Given this list of marker genes PGAP1, HECW2, CARS1, DNM2, MORC2, TUBB3, CWC27, IQSEC1, TRAPPC9, SATB1, SUPT16H, KDM5B, NEUROD2, SELENON, GJA1, COL3A1, LIPT2, POMT2, GJC2, NFIA (NCBI Gene Id 4774), MBTPS1, ATP10A, BSND, KMT2C, CYP3A4, CPLX1, ZNF407, AP4E1, FBLN1, SPG11, FUS, SLC18A2, CLCN7, CUL3, P4HTM, OTUD7A, CACNA1C, TAF1, FOXP1, KLHL15, MECR, LSS, COL6A3, YARS1, GET4, TNRC6B, NGLY1, AMPD2, LAMA2, CAMK2A, HS6ST2, FITM2, ATP6V1A, FNIP1, SLC37A4, CSNK2A1, POMT1, GAA, WASHC4, CHRND, SCN4A, EIF2B4, GALNT2, ZC4H2, NCAPG2, OTUD6B, MTPAP, CFL2, CTNNA2, MBD5, VPS51, PGAP3, EXOC6B, XYLT1, AGRN, BCORL1, ASXL3, MYO9A, YIF1B, DPH2 (NCBI Gene Id 1802), PLEC, COASY, KCNK4, CCDC22, SMC1A, ALG12, TPM2, PPP2CA, HNRNPK, CNOT3, GLS, MMAB, CACNA1G, MBOAT7, COG1, MAPK8IP3, RTN2, LNPK, PUM1, CDKL5, TBR1, LRP5, NMNAT1, NEXMIF, LARS1, CRBN, TTN (NCBI Gene Id 7847), ZNF142, VPS35L, FIG4, PAFAH1B1, CADM3, FDXR (ferredoxin reductase), PRIM1, TNFRSF11B (NCBI Gene Id 4982), CHRNB1, PNP, PLAA (NCBI Gene Id 9373), SCO2, LMNB1, MUSK, BRAT1, PACS2, PHKG2, STAG2, SET, CHAMP1, DDOST, SON, FLVCR1, EIF4A2, CDC40 (NCBI Gene Id 51362), SLC39A8, SLC12A2, POLR1A, KCNA4, TMEM94, BCL11A, SLC25A12, MARS1, TSEN15, ACTA1, RAB11B, COL2A1, EIF2AK1, ZEB2, CUBN, DHPS (NCBI Gene Id 1725), CLCNKA, DYNC1I2, ADCY5, VLDLR, PHEX (phosphate regulating endopeptidase X-linked), CHMP1A, KDM4B, POLR1C, TNPO3 (transportin 3), NUBPL, WLS, GALE, MYT1L, BIN1, NAT8L, SLC31A1, RBPJ, DLK1, RETREG1, EXTL3, OGDH, HNRNPC, BMP1, ATG7, DOK7, JAG1, MINPP1 (NCBI Gene Id 9562), MECP2, CIT, SMARCD1, GALNS, PPP2R5D, WDR4, TMEM63C (transmembrane protein 63C), FMR1, SIK3, TMEM163, TRIM2, HMBS, KDM1A, SNX14, RNU4-2, NCDN, RYR1, SIGMAR1, SCN2A, KMT2E, SEMA6B, CRELD1, KIF14, KY (kyphoscoliosis peptidase), LMNB2, ATP1A1, HARS1, FBXO11, POMK, KAT6A, CHRNA1, MKS1, PPP2R1A, WDR81, FRMPD4, KIAA0753, HDAC4, ASCC3, COL12A1, DLAT, H3-3A, TRPM3, CTBP1, SCAF4, RTL1, SDHB, UBE3A, NTNG1, TAF4, TRNT1, PIEZO2, TTC5, FGF3, NAA10, SOX4 (SRY-box transcription factor 4), SELENOI, AP1S2, UBE2A, AMN, DAG1, RUBCN, RALA, CLDN11, GPRC5B, KLC2, RORA, CNKSR2, MEGF8, FLRT1, TRAPPC10, MYF6, MRPS14, SMARCA2, ALMS1, DPM3, GNPTAB, CCDC134, KARS1, ERLIN2, COL1A1, WDR45, RAB3GAP1, PAK3, SPTSSA, SLC16A2 (NCBI Gene Id 6567), LRP4, GRIA1, NFASC, SMPD1, PDE10A, DNASE2, SCN8A, RPL10, TIMM50, RNU12, BCL11B, TUBB2B (tubulin beta 2B class IIb), PAK1, PRMT7, AP4B1, PHOX2A, CSNK2B, VRK1, SPOP, CLCN3, COL13A1 (NCBI Gene Id 96775), CDK10, MPV17, MSL3, ROBO3, TRIT1, DPF2, CYP2U1, BRPF1, ADARB1, GARS1, HERC2, VPS13B (NCBI Gene Id 54990), AHDC1, HOXA1, FTH1, TTI2, SUCLA2, CREBBP, SLC25A1, TGFB3, BCAS3, SMC3, SLC25A42, NDUFA12, CHD3, MEG3, MESD, TTI1, SPTLC1 (NCBI Gene Id 3302), DCPS, SRRM2 (serine/arginine repetitive matrix 2), ARID1B, KIF21A, GABBR2, ODC1, SLC5A7, RBL2, RAI1, SNAP25, AHI1, POLR3K, SHOC2, POLR2A (NCBI Gene Id 5430), SLC9A7, HUWE1, ALS2, KPTN, MCM3AP, NDUFA8, EBF3, RYR3, CTCF, PPIB, FTSJ1, CHRNE, MTMR14, CHST3, IFT27, AK9, ABCA2, RAD51 (NCBI Gene Id 5888), EIF3F, SLC9A6, DMD, COL6A2, MYH7, GRIN2B, HYCC1, MRPS25 (mitochondrial ribosomal protein S25), CHST14, PMPCA, TRIM8, DYNC1H1, AP4S1, YY1, GRIN1, ESAM, PLOD1, TNNT1, PIGG, CNTNAP2, KMT2A, PIGO, SLC9A1, CELF2, FUCA1, MEF2C, TRMU, PHKB, AP3B2, CHKA, CLCNKB, SETD5, RAB3GAP2, MID1, FOXG1, ROGDI, INPP5E (inositol polyphosphate-5-phosphatase E), KDM3B, LARGE1, DOCK3, FBXL3, DNAJC19, SPARC, ABCB7, TRAPPC6B, ZNF148, ITPR1, MPZ, PIGC, POGZ, MRAS (muscle RAS oncogene homolog), VAMP1, SPTBN4, DOLK, MDH2, DSE, KPNA3, SLC6A3, TMEM63A, FKBP14, SHMT2, TAMM41, MT-TE, PLP1, LBR, POLR3B, FKRP, NDUFA1, NBEA, TK2, TRIO, KIDINS220, EP300, GNAI1, APC2, OPHN1, CCNK, AGO1, PUS7, TFG, PTEN, CLPB, SNRPN, CASK, PI4KA, NPHP1, HK1, ZSWIM6, EHMT1, MED13, NFU1, ACBD6, COL1A2, DHX30, UGDH (NCBI Gene Id 7358), KAT8, FAR1, ZBTB11, GRIK2, MFN2, ARL13B, NEDD4L, PGM2L1, COPB1, TUBA1A, ACTN2, NFIX, PCYT2, RUSC2, TAF8, LMNA, DPYSL5, TANGO2, CCBE1, SYNE1, ATP6V0A1, SRCAP, NONO, TRRAP, MACF1, CDH2, FASTKD2, NDST1, GRIA4, WDR26, HIVEP2, TRMT1, TMEM222, LRRC32, CDK13, PHKA2, WASF1, TCF20, SYT1, ADGRL1, TET3, CTNNB1, NUDT2, TMEM106B, TMEM147, COL25A1, PNPLA2, MAGEL2, NARS1, ATG5, TMTC3, RAPSN, ZFX, CLP1, here is a description of the gene set: A type of motor delay characterized by a delay in acquiring the ability to control the large muscles of the body for walking, running, sitting, and crawling. Delayed gross motor development studied in species Homo sapiens Human Gene Set: HP_DELAYED_GROSS_MOTOR_DEVELOPMENT